Given this list of marker genes LGALS9, TRIM38, TMPRSS2, KPNA6, TRIM21, TSG101, TYRO3, FMR1, CLEC4G, FURIN, TRIM11, CD209, SMPD1, HMGB1, TMPRSS4, HLA-DRB1, AXL, KPNA2 (karyopherin subunit alpha 2), CD4, BSG, LGALS1 (NCBI Gene Id 3956), VPS37B, P4HB, CD74, VPS4A, here is a description of the gene set: Any process that activates or increases the frequency, rate or extent of viral life cycle. species: Homo sapiens Human Gene Set: GOBP_POSITIVE_REGULATION_OF_VIRAL_LIFE_CYCLE